The following is a description of a gene set: species: Mus musculus Mouse Gene Set: GOMF_TELOMERIC_D_LOOP_BINDING Binding to a telomeric D-loop. A telomeric D-loop is a three-stranded DNA displacement loop that forms at the site where the telomeric 3' single-stranded DNA overhang (formed of the repeat sequence TTAGGG in mammals) is tucked back inside the double-stranded component of telomeric DNA molecule, thus forming a t-loop or telomeric-loop and protecting the chromosome terminus., and this is the list of marker genes: Recql4, Blm (NCBI Gene Id 12144), Wrn, Pot1a, Pot1b